Given this list of marker genes HORMAD1, THBS3, DKK4, IFRD1, ATE1, DEFA6, LRRC45, JUN, CCT3, SH3BGRL2, BIRC5, SEC31B, CBFA2T3, MYBL2, IL16, CSAG2 (CSAG family member 2), TYRO3, ALDH7A1, THADA, C19orf25, KMT2D, FXYD3, MED1, NIPSNAP3B, MAPK13, TAPBP, GOLPH3L (golgi phosphoprotein 3 like), NEK9, RCC2, REG4, PRKAG1, ATP5IF1, ETS2, BRD4 (NCBI Gene Id 90616), NOP14, PRICKLE3, MMP10, DEFA5, MIA, RPL8, A4GNT, STAT2, OLFM4, SRSF9, CYP2W1, HOXA10, ZWILCH, TPT1, AQR (aquarius intron-binding spliceosomal factor), KIF4A, SULT1C2, TMLHE, here is a description of the gene set: Gastric cancer (GC) is one of the most common malignancies worldwide. Genes expressed only in cancer tissue will be useful molecular markers for diagnosis and may also be good therapeutic targets. However, little is known about cancer-specific genes, at least in GC. In this study, we searched for GC-specific genes by serial analysis of gene expression (SAGE) data analysis and quantitative reverse transcription (RT)-PCR. Comparing GC SAGE libraries with those of various normal tissues in the SAGEmap database, we identified 54 candidate GC-specific genes. Quantitative RT-PCR analysis of these candidates revealed that APin protein (APIN), taxol resistance-associated gene 3 (TRAG3), cytochrome P450, family 2, subfamily W, polypeptide 1 (CYP2W1), melanoma inhibitory activity (MIA), matrix metalloproteinase-10 (MMP-10), dickkopf homolog 4 (DKK4), GW112, regenerating islet-derived family, member 4 (REGIV), and HORMA domain-containing 1 (HORMAD1) were expressed much more highly in GC than in 14 kinds of normal tissues. Immunohistochemical staining for MIA, MMP-10, and DKK4 was found in 47 (31.1%), 68 (45.0%), and two (1.3%) of 151 GCs, respectively, and staining for both MIA and MMP-10 was correlated with poor prognosis in advanced GC (P=0.0001 and 0.0141, respectively). Moreover, enzyme-linked immunosorbent assay showed high levels of MMP-10 (65/69, 94.2%) in serum samples from patients with GC. Levels of MIA were raised in a small proportion of serum samples from patients with GC (4/69, 5.8%). In Boyden chamber invasion assays, MIA-transfected GC cells were up to three times more invasive than cells transfected with empty vector. Taken together, these results suggest that MMP-10 is a good marker for the detection of GC and that MIA and MMP-10 are prognostic factors for GC. As expression of MIA and MMP-10 is narrowly restricted in cancer, these two molecules may be good therapeutic targets for GC. Selected genes specifically expressed in gastric cancer. Human Gene Set: AUNG_GASTRIC_CANCER from publication Aung PP, Oue N, Mitani Y, Nakayama H, Yoshida K, Noguchi T, Bosserhoff AK, Yasui W (PMID 16331256) studied in species Homo sapiens